The following is a description of a gene set: species: Homo sapiens Human Gene Set: GOMF_UBIQUITIN_PROTEIN_TRANSFERASE_INHIBITOR_ACTIVITY Binds to and stops, prevents or reduces the activity of a ubiquitin-protein transferase., and this is the list of marker genes: RPS15, LIMK1, BAG5, RPL23, CDKN2A, RPL5, RPL11, ARHGAP5-AS1, FBXO5, RPS20, PARK7, OTUB1, HTRA2, SPRY2, RPS7, RPL37, GLMN